Given this list of marker genes MED13L, DVL1, BCL11B, YWHAE, SRCAP, CAV1, KDM6B, RSPO2, SET, TRIP12, UBE3B, ATAD3A, MAPK8IP3, UBE4B (NCBI Gene Id 10277), CLCN3, KCNJ8, PIGN, PAFAH1B1, SLC25A24, LARP7, CCND2, SOX4, RIPK4, ADAT3, KARS1, PCGF2, CACNA1C, CENPT, DHCR24, HECW2, SF3B2, TNNI2, INSR, PAX3, PSPH, ZNF526, TALDO1, GNAI3, EDN1, PMM2, GTF2I, SUPT16H, OTX2, SH2B1, MYH3, SOX11, ECEL1, FBXO11, PHACTR1, WDR4, WDR73, BUD23, ALDH18A1, HS2ST1, ZMYND11, FLNA, NEXMIF, SMS, MYT1L, MECP2, MED12, ASXL1, SMARCE1, POLR1D, MED12L, MBD5, BBS7, TBC1D20, RECQL4, TMLHE, ATPAF2, SEMA3E, KLHL15, PIEZO2, FBN1, MMP23B, TRPM3, SEPTIN9, FAM20C, LIG4, SLC6A1, CHD6, CUL4B, TWIST2, CAMK2A, DONSON, MIPEP, KIF15, COL11A2, PTEN, RERE, SKIC3, ATP6V1E1, AKT1, BIN1, POLR1C, CENPF, LEMD2, RNH1, ALG9, TBL2, HECTD4, MYL11, TRMT5, TMCO1, KIF7, BMP2, ARID1B, DNAJC30, RALGAPA1, STX1A, COL2A1, GPC4, KDM3B, RPL10, AGA, MAPRE2, POLR1B, CRLF1, IDUA, EXTL3, TUBB, LMX1B, RAI1, THUMPD1, MKS1, H4C11, UFC1, MMP1, BCR, ACTG1, PLCB4, ZSWIM6, CCBE1, CDK19 (NCBI Gene Id 23097), SETD1A, CDT1, B3GAT3, IGF1R, PGAP2, RNF125, NEB, AUTS2, FGFR2, ACTB, GTF2IRD2, PQBP1, GNPTAB, AFF3, DYM, APC, EIF4A2, DPYD, QRICH1, NSUN2, PIGL, SP7 (NCBI Gene Id 121340), CAMTA1, LIMK1, TRRAP, NEDD4L, SOS1, GNS, CDC6, ZFX, KCNK4, MGAT2, FKBP6, LUZP1, SIN3A, H4C3, TXNL4A, EIF4H, MEG3, DPF2, PRKCZ, CTCF, BPTF (NCBI Gene Id 348241), TBX1, NAA80, MED13, POLR3A, ABCC9, PPP1R15B, ADSL, NRXN1, ZNF148, SMARCA2, DCHS1, TMEM147, AP4B1, RAB3GAP1, LTBP3, OCA2, MAP3K7, GTF2IRD1, SOX9, RNU12, SNIP1, SLC12A2, HIRA, MYBPC1, GRB10, AP4E1, POGZ, ELN, SCARF2, VPS37D, ADNP, TMEM70, MDM2, RREB1, RNF113A, NONO, PDPN, ACTL6B, UBE3A, CD96, SPEG, SLC26A2, LZTR1, CDK13, ATRX, SF3B4, IARS2, ADAMTS3, TASP1, COL3A1, UFD1, WNT3, POLA1, KAT6A, TAF6, TMEM67, LGI3, COL7A1, PRDM16, ARID1A, KCNAB2, ERLIN2, SMARCC2, TPM2, BPNT2, STRADA, DACT1, BAZ1B, CDC42BPB, AMMECR1, AKT3, CRKL, ITGA3, SATB2, HEATR3, PIGU, EIF4A3, CHST3, SPEN, WAC, MCM5, COG1, B4GALT7, DLK1, AP1S2, GLB1, CHRNG, NCF1, RFC2, FILIP1, SNRPN, B3GLCT, KCNH1 (potassium voltage-gated channel subfamily H member 1), MADD, PIGF, DCPS, PTCH1, KCNN3, STAG1, PPM1D, SCNM1, STXBP1, HUWE1, RNF2, CHSY1, ZMIZ1, SEC23A, TRMT10A, FOXP2, UBE2A, SSR4, RPS6KA3, GABRD, CDC42, BMPR1A, ATP10A, INTS11, CRELD1, CLCF1, IFT140, H4C5, H3-3A, TNNT3, POU4F1, CHD7 (chromodomain helicase DNA binding protein 7), COMT, GNB2, PGAP1, RLIM, HSPG2, AP4M1, PIK3CA, CNTNAP2, AP2M1, GABRA3, GBA1, TTN, FAT4, TRIO, METTL27, SALL1, POR, MUSK, PIGA, TMEM270, TLK2, DDX11, FLCN, RYR1, SCYL2, PACS2, MAP2K1, CHD2, ATIC, IRX5, AHDC1, ASXL3, DSE, POLD1, GSC, MTX2, AP4S1, WLS, GMNN, KAT5, EXOSC5, ATP6V1B2, BRPF1, SMARCD1, TBX4, PRPS1, HDAC9, NFIA, ORC4, PRRX1, RTTN, NFIX, PTDSS1, ARVCF, ADAMTSL2, SMAD4, MAPK1, GALNS, RAF1, CDC45, CREBBP, SETBP1, GPC3, PACS1, KATNB1, TCF4, LMNA, ZMPSTE24, SCN1A, HDAC6, ROR2, DDB1, DHCR7, HNRNPH2, PIK3R2, SH3PXD2B, SLC2A1, CANT1, OSGEP, TGDS, ANKRD11, TWIST1, GATAD2B, SOX6, ZBTB20, FREM2, DPYSL5, GP1BB, KMT2B, SYNGAP1, NR2F1, RNU4-2, JMJD1C, MTOR, SMARCA4, SKI, CEP57, CCDC47, WDR26, SPRED2, CASZ1, TRIP4, KCNMA1, ORC6 (NCBI Gene Id 23594), SON, NXN, CLIP2, ARID2, HIVEP2, MAF, CA2, EP300, GJA1, NOTCH2, ATP6V0A2, TP63, CHST14, NALCN, ORC1, TCOF1, ZNF699, PIGB (phosphatidylinositol glycan anchor biosynthesis class B), SEC24C (NCBI Gene Id 9632), NMNAT1, RTL1, COG7, SMARCB1, COL11A1, here is a description of the gene set: Human Gene Set: HP_ABNORMALITY_OF_MOUTH_SIZE Abnormality of mouth size species: Homo sapiens